The following is a description of a gene set: Mouse Gene Set: MIR_6966_3P Genes predicted to be targets of miRBase v22 microRNA mmu_miR_6966_3p in miRDB v6.0 with MirTarget v4 prediction scores > 80 (high confidence targets). from publication Chen Y, Wang X (PMID 31504780) studied in species Mus musculus, and this is the list of marker genes: Ptprb, Cyth4, Rprd1a, Hexim2, Acss3, Atp7a, Lrch3, Mfsd11, Klhl17, Tcaf3, Brwd1, Tpx2, Nipal3, Iqsec1, Rbm39, Zfp704, Prox1, She, Adcy1, Nfasc, Htr2c, Xpnpep3, Tppp, Ocrl, Myrf, Nfib, Vps54, 2510009E07Rik, Hecw2, Gabrb2, Ces2g, Fam229a, Ywhae, Zmym2, Zfhx4, Hmga2, Dnah17, Inpp4b, Pgap4, Slc24a2, Gas2l1, Ahi1, Atp2b1, Aen, Tmem245, Syt1, Taok1, Unc5a, Nup214, Oprm1, Pigk, Kifc2, Tmtc1, Mical2, E2f8, Fam76b, Wif1, Fcho2, Bptf, Serpine1, Kcna2, Ccdc39, Slu7, Gdnf, Rnf13, Deptor, Cd33, Atrx, Rab7, Zzz3, Zfp647, Nlrp5, Stk4, Gucd1, Ctso, Evx1, Tnks2, Pknox1, Tafa3, Nsg2, Slc25a42, Steap2, Trim67 (tripartite motif-containing 67), Ufsp1, Fam118b, Pik3c2a, Numbl, Klf13, Cask, Atp2b2, Crls1, Gucy1a2, Tesk1, Zfp462, Epha7, Stpg1, Car5b, Tmem87b, Loxl4, Aldh8a1, Tspan18, Arhgap18, Batf, Bop1, Dpp4 (NCBI Gene Id 13482), Mfsd6, Hipk3, Itga6, Abhd6, Fbxl2, Manea, Hey2, Cap1